Given this list of marker genes Slc4a10, Slc4a4, Slc4a9, Slc4a1, Slc4a2, Ahcyl2, Slc4a8, here is a description of the gene set: species: Mus musculus Reactome Pathway: Bicarbonate transporters This event has been computationally inferred from an event that has been demonstrated in another species.<p>The inference is based on the homology mapping from PANTHER. Briefly, reactions for which all involved PhysicalEntities (in input, output and catalyst) have a mapped orthologue/paralogue (for complexes at least 75% of components must have a mapping) are inferred to the other species. electronically inferred by orthology from the curated human pathway part of: SLC-mediated transport of inorganic anions